The following is a description of a gene set: A deviation from normal signal on magnetic resonance imaging (MRI) of the thalamus. Human Gene Set: HP_ABNORMAL_THALAMIC_MRI_SIGNAL_INTENSITY studied in species Homo sapiens Abnormal thalamic MRI signal intensity, and this is the list of marker genes: TRAF7, TWNK, MTRFR, TERT (NCBI Gene Id 7015), GTPBP3, BAP1, CLN8, GFAP, SMARCE1, SMO, PTCD3, TREM2, MFF, SCP2 (sterol carrier protein 2), HEXB, POLG, PIK3CA, SMARCB1, FTL, CP, NF2, COX10, SUFU, PDGFB, AKT1